Given this list of marker genes GMPPA, TENT4B, RNGTT, THG1L, TENT4A, GMPPB (GDP-mannose pyrophosphorylase B), FPGT, GDPGP1, here is a description of the gene set: Catalysis of the transfer of a guanylyl group to an acceptor. Human Gene Set: GOMF_GUANYLYLTRANSFERASE_ACTIVITY species: Homo sapiens